Given this list of marker genes Ccny, Pim1 (proviral integration site 1), Akt1, Prox1, Ccnd2, Egfr, Adam17, Psmd10, Ccnd3, Stil, Spdya, Stox1, Ttbk1, Spdye4a, Psrc1, Rgcc (regulator of cell cycle), Ccnd1, Mapre3, here is a description of the gene set: Mouse Gene Set: GOBP_POSITIVE_REGULATION_OF_CYCLIN_DEPENDENT_PROTEIN_KINASE_ACTIVITY studied in species Mus musculus Any process that activates or increases the frequency, rate or extent of cyclin-dependent protein kinase activity.